Given this list of marker genes SLC7A5P1, SRSF3, H2AZ1, TARDBP, HNRNPU, SUPT16H, SUMO2, EIF3L, PABPN1, XPO1, SRP72, KHDRBS1, NOP14, H2AZ2, PTMA, NCL, HNRNPR, ZNF22, SRSF2, SNRPE, DUT, FBL, HNRNPAB, RTRAF (NCBI Gene Id 51637), SF3B3, PPIH, DIMT1, NUP43, EXOSC8, SRSF1, EED, HNRNPA1, HINT1, PDS5A, MCM5, TRA2B, DHX15, ANAPC5, SNRPD1 (NCBI Gene Id 6632), APEX1, DKC1, NOLC1, SUZ12, MRPL16, COMMD3, HMGN2, ATP5MG, MRPL9 (mitochondrial ribosomal protein L9), WDR46, ARMCX6, RPL4, CHD1L, NOL11 (nucleolar protein 11), HNRNPA3P1, SYNCRIP, WDR41, U2SURP, POLE3, USP1 (ubiquitin specific peptidase 1), LSM7, CPSF6, TCERG1, U2AF1 (U2 small nuclear RNA auxiliary factor 1), SERBP1, MTF2, LSM5, HMGB1, NOP56, PPIA, ILF2, EIF3A, HMGN1, ATP5MC2, PES1, RBMX, NONO, PSMA6, TOPBP1, EIF3D, BTF3, SRSF10, IMPDH2, ATP5F1A, GRSF1, SRSF7 (NCBI Gene Id 87459), FUS, HNRNPC, PTBP1, SNRPD3, EPRS1, SSB, SFPQ, here is a description of the gene set: species: Homo sapiens Neighborhood of APEX1 Neighborhood of APEX1 APEX nuclease (multifunctional DNA repair enzyme) 1 in the GNF2 expression compendium Human Gene Set: GNF2_APEX1